The following is a description of a gene set: Mouse Gene Set: GOBP_PURINE_NUCLEOSIDE_MONOPHOSPHATE_CATABOLIC_PROCESS The chemical reactions and pathways resulting in the breakdown of purine nucleoside monophosphate, a compound consisting of a purine base linked to a ribose or deoxyribose sugar esterified with phosphate on the sugar. studied in species Mus musculus, and this is the list of marker genes: Nt5e, Nt5c, Ampd3, Urah, Nt5c2, Pnp, Gmpr2, Gda, Hprt1, Nt5c1b, Xdh, Ada, Urad, Slc29a1, Entpd1, Nt5c1a (NCBI Gene Id 230718), Dnph1, Uox